Given this list of marker genes WNT4, ESR1, AR, MED1, CSMD1, VDR, PGR, here is a description of the gene set: studied in species Homo sapiens The process in which the branching structure of the mammary gland duct is generated and organized as a part of pregnancy. Human Gene Set: GOBP_MAMMARY_GLAND_BRANCHING_INVOLVED_IN_PREGNANCY